Given this list of marker genes DSG2, SNUPN, SUFU, ZIC2, FKRP, SLC5A7, BSCL2, MYPN, TRIM32, SLC18A3, CENPF, SQSTM1, TRIP4, MT-ND4, RAF1, GIPC1, ALG14, COQ4, DYSF, ORAI1, AP1S2, CHAT, DNAJB4, TANGO2, PTCH1, CRYAB, SGCD, ELN, CHRNE, MMP23B, ACACA, RPL3L, HADHA, VAMP1, SCO2, CTNS, TGIF1, MT-ND1, NEFL, KBTBD13, NEXN, MYH14, XK, MSTO1, HSPG2, FGF8 (NCBI Gene Id 2253), MYOT, TBL2, MT-TS2, MYH2, NODAL, ADGRG6, TXNRD2, RET, SCN4A, CLCN1, COL13A1, ADSS1, NDUFAF1, NDUFAF4, FHL1, CRIPTO (cripto, EGF-CFC family member), GFPT1, ACTC1, ALG2, DES, PLEC, EPG5, CAP2, MYH6, DHX16, PRDM16, PGK1, SLC25A3, MTTP, BAG5, MATR3, RYR1, FHL2, CFL2, HADHB, COL9A2, LAMP2, DCC, OPA1, TAFAZZIN, PGAM2, AKT1, TNPO3, MT-TI, TKFC, HNRNPA1, COL6A3, UNC80, PTEN, AGL, NALCN, MYO9A, SDHB, PSEN1, GK, GTF2I, FRG1, JAG2, DNA2, PABPN1, KCNAB2, DOLK, CDON, ACTA1, SYT2, DNM2, COL6A1, NDUFA11, MYBPC1, MPV17, FKBP14, SDHD, ALPL, PPARG, MYMK, JPH2, SELENON, CASZ1, AMPD1, MT-RNR1, LRP12, MAN2B1, POLG, MYMX, RRM1, MYF6, VEZF1, GFER, UBA1, KLHL9, AGRN, BAG3, RILPL1, CHKB, MT-TK, MT-CYB, SDHA, TMEM270, TNNT1, NDUFS2, PSEN2, FXR1, TIA1, TNNT2, TNNC1, GTF2IRD1, SHH, MEGF10, VPS13A, VCP, FLAD1, EIF4H, XDH, MT-TC (NCBI Gene Id 4511), MUSK, TPI1, MYOD1, TNNI3, CHCHD10, TMPO, RRM2B, RERE, DNM1L, TBCE, MTAP, PNPLA2, MT-TV (mitochondrially encoded tRNA-Val (GUN)), MGME1, RFC2, ACADM, MT-TP, MT-TT, DOK7, CRPPA, DSP, CLIP2, PPCS, MT-ATP6, SGCB, COMP (NCBI Gene Id 5659), MT-ND4L, MT-TL1, LMOD2 (leiomodin 2), MTMR14, MT-TH, RMND1, NUBPL (NCBI Gene Id 80224), EMD, SMCHD1, LUZP1, RAPSN, TK2, UNC45B (NCBI Gene Id 191583), SNAP25, ABHD5, ACADS, CAV3, LIPE, SKI, CHST14, MT-TQ, COL6A2, TWNK, TPM1, YARS2, GMPPB, LMNA, POMT1, MT-ND5, DMD, CHRND, NEFH, GNE, MT-CO3, DLL1, LRP4, TPM3, CPT2, LARGE1 (LARGE xylosyl- and glucuronyltransferase 1), PHKA1, SGCA, ANO5, TRMU, MT-TW, NARS2 (asparaginyl-tRNA synthetase 2, mitochondrial), VWA1, GLI2, ROBO3, LAMB2, FKTN, SCN5A, C1QBP, MYO18B (NCBI Gene Id 84700), DPM3, TPM2, PANK2, GTF2IRD2, PRKCZ, DNMT3B, GAS1, POMT2, CHRNB1, SPEN, ABCC9, DISP1, BAZ1B, TAF1A, GYG1, MYBPC3, MT-CO1, HNRNPA2B1, STIM1, MT-TE, TRAPPC11, LIMK1, COL9A3 (collagen type IX alpha 3 chain), PRKAG2, MT-ND6, METTL27, HAND2, VPS37D, PDPN, SAR1B, ACTN2, GABRD, GET3, SYNE2 (spectrin repeat containing nuclear envelope protein 2), SYNE1, SLC22A5, CCDC174, RBM20, SIL1, GCLC (glutamate-cysteine ligase catalytic subunit), NCF1, ERGIC1, MT-TF, HNRNPDL, UBE4B, ISCU, CASQ1 (calsequestrin 1), TCAP, B4GALT1, FLNC, BUD23, CISD2, SGCG, CAPN3, SLC25A4, BIN1, VMA21, LDB3, G6PC3, LMOD3, DUX4 (double homeobox 4), SIX3, COLQ, AGK, PLN, PHKG1, POMGNT1, B3GALNT2, PUS1, KLHL40, DUX4L1, NDUFB3, ACAD9, LMNB2, CHRNA1, WFS1, TTN, POLRMT, CSRP3, POLG2, SDHAF1, CACNA1S, VCL, NEB, MYH7, LAMA4, SVIL, MT-ND2, DNAJC30 (DnaJ heat shock protein family (Hsp40) member C30), PLOD1 (NCBI Gene Id 5351), FGFR1, COL12A1, TMEM43, MT-CO2, KLHL41, FKBP6, SLC25A1, DSE, ALDOA, AK9, FOXH1, DPAGT1, DNAJB6, STX1A, ZBTB20, GATAD1, COL9A1, ANKRD1, here is a description of the gene set: Myopathy species: Homo sapiens A disorder of muscle unrelated to impairment of innervation or neuromuscular junction. Human Gene Set: HP_MYOPATHY